Given this list of marker genes MPV17, CEP41, HINT1, ACBD6, RAD51C, PIGN, BBS10, SEMA3D, SEC24C, TMEM218, ERCC3, SNTA1, FOXH1, HYCC1, SCN3A, GABRA3, FLVCR1, SAMD12, NEU1, REEP1, BBS12, GIGYF2, PGAP2, COL5A2, MMEL1, GFAP, CEP104, MARCHF6, STARD7, SCN5A, BCOR, COMT, LIFR, CEP19, NDRG1, LEP, BRCA2, ABHD12, CYP11B2 (NCBI Gene Id 1585), XRCC2, KCNE1, PEX6, EMILIN1, SPG7, MBTPS2, DHH, SLC18A2, RREB1, MKS1, FGFR1, IFT172, COL6A1, CC2D2A, SMC1A, KATNIP, TMEM138, TGIF1, FANCE, PNPT1, NSD1, APC2, VCP, LMO1, TCTN2, ERCC4, SCP2, PAX3, FBN1, FANCI, CCDC28B, TRPV4, NOTCH2NLC (notch 2 N-terminal like C), OPA1, SEPTIN9, FANCG, NODAL, SNAI2, NFASC, KITLG, TCTN1, MEGF10, PRPS1, RFWD3, SORD, IFT27, DBH, DNAJB6, MOGS, GSN, MFN2, CACNA1S, GLA, AARS1, BBIP1, KCNJ5, DNAJC13, FBLN5, SIGMAR1, SPTBN4, PRNP, FANCL, SCN4B, CADM3, RAI1, DHCR7, SBF2, TBX1, LYST, CALM3, PINK1, TUBB3, AHI1, LAMA2, SCLT1, HACE1, PSAP (prosaposin), EIF4G1, NTRK1, TTR, IDUA, VPS13A, FMR1, HSPB1, GDNF, HSD17B4, TMEM67, KIF1B, SAMD9L (sterile alpha motif domain containing 9 like), SOX10, MAPT, OFD1, GLI2, ARHGEF2, FXN, POU2AF1, SPG11, COL1A1, TBC1D20, CHCHD2, WDPCP, GDAP1, PHOX2B, PIGO, ASCL1, ARMC9, RET (NCBI Gene Id 5979), ACOX1, SPTAN1 (spectrin alpha, non-erythrocytic 1), MATR3, KCNQ1, HIKESHI, PRDX3, SYNJ1, BRAT1, CRIPTO, TBCK, CPLANE1, PARK7, NRTN, PTRH2, GARS1, HSPB8, ATP1A3, MYH3, COL5A1, MYO1H (myosin IH), TRIM32, ALS2, RELN, RETREG1, POLR3A, WNK1, LMNA, LITAF (lipopolysaccharide induced TNF factor), HPDL, ZNF423, EDN3, JPH1, PPOX, TYR, MECP2, TCF4, CYP27A1, PODXL, TTPA, HYLS1, ERBB2, B9D1, UBA1, LGI1, AIFM1, RAD51, TNPO3, ITPR1, CACNA1A, KCNJ18, SEMA3C, ATXN8OS, ERCC8, YME1L1, SLC1A3, ATP7B, SLC5A7, BBS7, CEP120, GBE1, ECE1 (NCBI Gene Id 1889), SNCA, FBXO38, KIAA0586, SHH, CEP126, PRX, ATXN3, SETX, SPTLC1, UCHL1, ATXN1, SDCCAG8, AAAS, RAD21, DIAPH3, CEP290, SACS, HK1, BBS4, POLG, CALM2, SH2B1, WDR45, TBC1D24, SBF1, LRRK2, FANCA, ARHGEF10, GALC, SLX4, FANCF, BBS9, NALCN, TPI1 (NCBI Gene Id 7167), DEGS1 (delta 4-desaturase, sphingolipid 1), CTDP1, CAV1, FANCB, SALL4, ZEB2, PLP1, PNKP, IGHMBP2, SCAPER, TMEM231, ANK2, GMPPA, ARL3, SETBP1, CNTNAP1, MPZ, RMRP, RAB7A, GFM2, MTRFR, OTOF, SMO, DEPDC5, DDX59, NR4A2, LRSAM1, HTRA2, SCN11A, SREBF1, GJC2, FLNC, PALB2, BBS5, LBX1, EBP, PMP22, TDP1, ABCD1, MKKS, ACTG2 (NCBI Gene Id 72), ATL3, FOXF1, ATRX, KIT, CRELD1, DNAJC3, GNB2, KIAA0753, MITF, FANCM, NOS1AP, NHLRC1, SLC12A6, ARVCF, SLC6A2, RIPOR2, CACNA1C, MYH14, BRCA1, LEPR, DCAF8, GP1BB, PIGW, IL12RB1, SPIB, SUFU, TOGARAM1, DLL1, PLOD1, ATL1 (NCBI Gene Id 6681), TBP, UBE2T, MT-TT, MED25, VPS13C, ALK, TRDN, PRKN, TMEM216, MORC2, TYMP, COQ2 (NCBI Gene Id 27235), KCNE2, TBX5, MFF, BDNF, PIGY, PGAP3, TUBA1A, DNM2, COMP, FGD4, HIRA, NPHP1, ADH1C, YEATS2, CYB561, DHX16, DDX3X, LIG3, NMNAT1, SIM1, SCN10A, IL12A, TXN2, SAA1, VPS11, NAA10, KIFBP, KCNH2, TFG (trafficking from ER to golgi regulator), EGR2, SYT2, TTC8, PLCH1, CHCHD10, LZTFL1, PDK3, AKAP9, CAV3, L1CAM (L1 cell adhesion molecule), MTMR2, TWNK, GABBR2, HEXB, DISP1 (dispatched RND transporter family member 1), TMEM237, VAMP1, FBXO7, IRF5, ZIC2, SF3B4, PIGV, BRIP1, ARX, FIG4, ATP11A, EPM2A, MYCN (NCBI Gene Id 53360), TRIM2, B2M, RRM2B, SYNE1, INPP5E (NCBI Gene Id 56623), ATXN10, CSPP1, FANCC, LMNB1, B9D2, SNAP29, RFC1, ARSA, FGF8, RPGRIP1L, ERCC6, CHRNA3, NPTX1, PTRHD1, WFS1, GBA1, MAD2L2, UFD1, KIF1A, UQCRC1 (ubiquinol-cytochrome c reductase core protein 1), SUCLA2, ELP1, PLEKHG5, ATXN2, GCK, LTBP3 (latent transforming growth factor beta binding protein 3), SLC6A8, BBS2, STAG2, ATP7A, VPS35, STIL, KARS1, IFT74, TNFSF15, PTCH1, SCN9A, SPTLC2, PIGL, CBY1, CALM1, CDON, NEFL, ARL6, SNCAIP, ARL13B, SH3TC2 (SH3 domain and tetratricopeptide repeats 2), DNAJC6, PLA2G6, DYSF (dysferlin), JMJD1C, ATP1A2, TSPYL1, TCTN3, RNF170, YARS1, GJB1 (gap junction protein beta 1), LIN28B, CFAP418, SEMA6B, SLC25A15, SPG21, BSCL2, FANCD2, TIMM8A, CISD2, ITPR3, KRAS, SUMF1, GAS1, NGLY1, PIBF1, ERBB3, BBS1, PMP2, PDE6D, CCT5, SIX3, EDNRB (endothelin receptor type B), here is a description of the gene set: Any abnormality of the part of the nervous system that consists of the nerves and ganglia outside of the brain and spinal cord. species: Homo sapiens Abnormality of the peripheral nervous system Human Gene Set: HP_ABNORMALITY_OF_THE_PERIPHERAL_NERVOUS_SYSTEM